Given this list of marker genes BIN1, IL6ST, MIR142, MYRF, LIF, TNFRSF1B, SHH, HDAC1, ZNF365, PRMT5, HDAC2, QKI, SERPINE2, TP73, RHEB, TTBK1, PTN, ZNF488, CXCR4, MDK, TENM4, IL34, CLCF1, BMP2, RNF112, NKX6-1, PTPRZ1, NKX2-2, ID2, OLIG2, EGR2, SPINT1 (serine peptidase inhibitor, Kunitz type 1), MTOR, CLCN2, NKX6-2 (NCBI Gene Id 84504, NK6 homeobox 2), GSX2, MAG, TGFB1, DICER1, RELA, DAG1, HES1, NOTCH1, here is a description of the gene set: Any process that activates or increases the frequency, rate or extent of glia cell differentiation. Human Gene Set: GOBP_POSITIVE_REGULATION_OF_GLIAL_CELL_DIFFERENTIATION species: Homo sapiens